Given this list of marker genes Lsm7, Lsm1, Lsm5, Lsm3, Lsm2, here is a description of the gene set: Mouse Gene Set: GOCC_LSM1_7_PAT1_COMPLEX A conserved, heteroheptameric, cytoplasmic protein complex composed of Lsm1, Lsm2, Lsm3, Lsm4, Lsm5, Lsm6, Lsm7, and Pat1, or orthologs thereof, that shows a strong binding preference for oligoadenylated RNAs over polyadenylated RNAs. May bind further associated proteins. Facilitates the deadenylation-dependent decapping of mRNA in the P-body thereby regulating mRNA decay and subsequent degradation by the 5' to 3' pathway. species: Mus musculus